Given this list of marker genes Ptprq, Ocrl, Inpp5k, Inpp5j (inositol polyphosphate 5-phosphatase J), Inpp5e, Tpte, Fig4, Inpp4b, Inpp5d, Pten, Inppl1, here is a description of the gene set: Catalysis of the reaction: phosphatidylinositol trisphosphate + H2O = phosphatidylinositol bisphosphate + phosphate. Mouse Gene Set: GOMF_PHOSPHATIDYLINOSITOL_TRISPHOSPHATE_PHOSPHATASE_ACTIVITY species: Mus musculus